The following is a description of a gene set: The division of a neuroblast located in the forebrain. Neuroblast division gives rise to at least another neuroblast. species: Homo sapiens Human Gene Set: GOBP_FOREBRAIN_NEUROBLAST_DIVISION, and this is the list of marker genes: ASPM, FGFR2, FGFR1, DCT, LEF1, WNT3A